The following is a description of a gene set: Cytokines mediate cell-cell communication in the immune system and represent important therapeutic targets. A myriad of studies have highlighted their central role in immune function, yet we lack a global view of the cellular responses of each immune cell type to each cytokine. To address this gap, the authors created the Immune Dictionary, a compendium of single-cell transcriptomic profiles of more than 17 immune cell types in response to each of 86 cytokines (>1,400 cytokine-cell type combinations) in mouse lymph nodes in vivo. A cytokine-centric view of the dictionary revealed that most cytokines induce highly cell-type-specific responses. For example, the inflammatory cytokine interleukin-1β induces distinct gene programmes in almost every cell type. A cell-type-centric view of the dictionary identified more than 66 cytokine-driven cellular polarization states across immune cell types, including previously uncharacterized states such as an interleukin-18-induced polyfunctional natural killer cell state. Mouse Gene Set: CUI_T_CELL_CD4_IL18_RESPONSE_UP Genes positively differentially expressed in cell type: CD4+ T cell upon treatment with cytokine: IL-18 in mouse lymph nodes in vivo. from publication Cui A, Huang T, Li S, Ma A, Pérez JL, Sander C, Keskin DB, Wu CJ, Fraenkel E, Hacohen N (PMID 38057668) species: Mus musculus, and this is the list of marker genes: Arid5b, Ms4a4b, Bcl3, Nmi, Rnf213, Socs3, Pml, Psmb9, Insl6, Smchd1, Irf1, Gbp4, Igfbp4, Iigp1, Gbp8, Gbp5, Phf11b, Zbp1, Tap2, Ifit3, Gimap4, Dbnl, Plaat3, Apobec3, Stat3, Usp18, Plgrkt, Gbp3, H2-T23, Slfn5, Trim12c, Parp9, Stat1, Ifi27l2a, Nlrc5, Mrps34, H2-T22, Psma4, Socs1, Icam1, Nampt, Ifi47, Ppa1, Psma7, Oasl2, Psme1, Dtx3l, Trim12a, Igtp, Ifit1bl1, Irgm1, Gbp2, Gbp6, Slfn1, Trim30a, Psma2, Parp14, Isg15, Idnk, Xaf1, Irf9 (NCBI Gene Id 16391), Ndrg3, Mthfd2, Irf8, Ccnd2, B2m, H2-K1, Calhm6, Bst2, Gbp9, Ms4a6b, Ifi203, Kbtbd11, Psme2, Gbp7, Samd9l, Ly6e, Isg20, Rtp4, Pim2, Tapbpl, Psmb8, Ssbp4, Stat2, Irf7, Notch1, Ifi35, Psmg4, Ms4a4c, Samhd1 (SAM domain and HD domain, 1), Treml2, Tap1, Tgtp2, Ctss, Ifi206, Psmb10, Sp110, Mndal, Ly6a, Sp140, Casp8, Cd274, Ifit1, Irgm2, Mitd1, Tapbp, Eif5a, Tgtp1, Ifi213, Ly6c1